Given this list of marker genes Mmp3, Hras, Cckbr, Mapk7, Grb2, Egfr, Gast, Mapk3, Prkca, here is a description of the gene set: electronically inferred by orthology from the curated human pathway This event has been computationally inferred from an event that has been demonstrated in another species.<p>The inference is based on the homology mapping from PANTHER. Briefly, reactions for which all involved PhysicalEntities (in input, output and catalyst) have a mapped orthologue/paralogue (for complexes at least 75% of components must have a mapping) are inferred to the other species. species: Mus musculus part of: G alpha (q) signalling events Reactome Pathway: Gastrin-CREB signalling pathway via PKC and MAPK